Given this list of marker genes ACE2, IL12A, IL1A, IFNG, IL18, TMPRSS2, IL2, IL6, FURIN, IL1B, TLR3, CXCL8, IL10, IFNA2, GFAP, CCL11, HMGB1, TLR7, TLR8, TLR4, IL4, MAPK1, TNF, here is a description of the gene set: Post-COVID neuroinflammation studied in species Homo sapiens Human Gene Set: WP_POSTCOVID_NEUROINFLAMMATION